The following is a description of a gene set: Homology Directed Repair Mouse Gene Set: REACTOME_HOMOLOGY_DIRECTED_REPAIR studied in species Mus musculus, and this is the list of marker genes: Rad52, Abl1, H2bc14, H2bc21, H2bc13 (H2B clustered histone 13), Trp53bp1, Brcc3 (NCBI Gene Id 210766), Pole3, Pold4, H4c6, Rfc1, Topbp1, Polq, Rad51c, H4c3, Brip1, Rfc3, Abraxas1, Wrn, Rad9b, Pold3, Rfc5, Rad51b, Xrcc2, Rps27a, Sirt6, Ube2n, Dna2, Eme1, H2ax, Rad51d, Ube2v2, Polk, H4c2, Mdc1, Rpa3, Rad1, Chek1, Babam1, Pold1, Rnf4, H2bc3, Ccna1, H2bc7, Top3a, H2bc24, Uimc1 (ubiquitin interaction motif containing 1), Fen1, H4c4, H2bc4, Blm, Rmi2 (NCBI Gene Id 436337), H2bc9, Pold2, Rad51, Rad9a, Rhno1, Rpa2, Fignl1, Ubc, Parp1 (NCBI Gene Id 98479), Xrcc1, Sumo2, Exo1, Pias4, Pole2, Rmi1, Kat5, Ube2i, Nbn, Uba52rt, Pole4, Uba52, H2bc11, Ppp4c, H2bc23, Nsd2, Ercc1, Ercc4, Babam2, Rnf168, Slx1b, Mre11a, Ccna2, Polh, Timeless, H4c11, Lig3, Brca1, Rad50, H2bc6, Atm (ataxia telangiectasia mutated), Pcna, Herc2, Rad51ap1, Hus1, Mus81, Rbbp8, Gen1, Cdk2, H2bc12, H4c9, H3f4, Rfc2, Xrcc3, Bard1, Rnf8, H2bc22, Rfc4, H4c1, Parp2, Rad17, Ppp4r2, Atrip, H2bc1, Eme2, Spidr, Brca2, H4c16, Clspn (NCBI Gene Id 97173), H2bc15, Tipin, H4c12, H4c18, H2bc26, Firrm, H4c14, H4c17, H4c8, Rpa1, Ubb, Pole, Slx4, H2bc8, Palb2